The following is a description of a gene set: Human Gene Set: GOBP_NEGATIVE_REGULATION_OF_SIGNALING_RECEPTOR_ACTIVITY Any process that stops, prevents or reduces the frequency, rate or extent of a signaling receptor activity. studied in species Homo sapiens, and this is the list of marker genes: RAMP3, SNX6, SOCS5, CNRIP1, ZFYVE28, VPS25, CHMP6, GPRC5A, CLEC12B, TSG101, CRHBP, ERRFI1, SOCS4, ZGPAT